Given this list of marker genes MKNK2, SP100, CIB1, BAG3, BMP4, BCL2L2 (NCBI Gene Id 599), GPER1, TERT, WWOX, FAIM, TLR6, IL1B, TNFRSF10C, KRT18, NRG1, MAPK7, GATA1, RAF1, ITGAV, SNAI2 (NCBI Gene Id 6591), G0S2 (G0/G1 switch 2), PDIA3, ACSL5, TNFSF15, PPP2R1B, IL19, SCRT2, AKT1, ZSWIM2, CD40LG, ZMYND11, NOS3, SGPP1, PTPRC, TLR3, HTT, SERPINE1, TNFRSF10B, SPI1, BEX3, SORT1, STK3 (serine/threonine kinase 3), LMNA, FAIM2, STX4, LGALS3, TNFSF11, IFI27, GPX1, TRAF2, RBCK1, DAXX, SIAH2, UNC5B, MCL1, LCN2, TNFRSF1A, IL2, IL1A, DBH, HGF, CD70, IL7, BOK, JAK2, GABARAP, PAK2, CASP8AP2, BAX, TGFB2, APP, FASLG, ZDHHC3, STK4, HSPA1B, NDUFA13, FADD, SMAD4, IFI6 (NCBI Gene Id 2537), TNFRSF1B, PHIP, FEM1B, GSK3B, AGTR2, SFRP2, HTRA2, FAF1, GCLM, RELA, PARP2, PPP2R1A, CX3CL1, PSME3, DDX3X, MIR221, TNFSF12, NGF, RNF34 (ring finger protein 34), LTA, ARHGEF2, BCL2L14 (BCL2 like 14), RB1CC1, PRDX2, TNFAIP3, NRP1, BCL2A1, SIVA1, BMPR1B, BCL10, SMAD3, MIR142, CFLAR, PMAIP1, GFRAL, HIPK1, MIR199A1, DEDD, SH3RF1, SGK3, GDNF, EYA1, SRPX, NF1 (NCBI Gene Id 646021), TNFRSF12A, TCF7L2, FGFR1, CAV1, KLF4, EYA4, BLOC1S2, LTBR, TRADD, RPS6KB1, DAB2IP, PAK5, FYN, RNF41, BCL2L11, MIR222, SFRP1, BAK1, DIABLO, FAS, TLR4 (toll like receptor 4), NGFR, TNF, CTNNA1, ITM2C, MAP2K5, TMBIM1, GRINA, P2RX7, ITGA6, COL2A1, BAD, EYA2, PF4, INHBA, SKIL, PELI3, BCL2L1, CD27, IFNG, RET, DEPTOR, TRAF1, PDPK1, BRCA1, MADD, CASP8, PEA15, ERBB3, DDX47, STRADB, ACVR1, BID, LTB, DELE1, KRT8, CYLD, TMC8, FGB, IGF1, FGFR3, BCL2, MOAP1, C8orf44-SGK3, RIPK1, MLLT11, TNFSF10, GCLC (NCBI Gene Id 2729), FGA, BMP5, KITLG, NFKBIZ, FOXO3, PIK3R1, AR, CASP2, IL33, IL6R, HMGB2, TGFB1, MAL, HSPA1A, BCL2L10, NOL3, DAPK1, ATF3, HMOX1, PPP1CA, PML, ICAM1, DEDD2, CSF2, PIDD1, GSTP1, THBS1, SCG2, ITPRIP, ACVR1B (activin A receptor type 1B), GSK3A, AGT, PARK7, TNFRSF10A, PYCARD, TGFBR1, IL12A, BIRC6, FGF10, TNFSF14, CRADD, YAP1, RFFL, EYA3, HYAL2, CTTN, FGG, SRC (NCBI Gene Id 6714), here is a description of the gene set: Human Gene Set: GOBP_EXTRINSIC_APOPTOTIC_SIGNALING_PATHWAY studied in species Homo sapiens The series of molecular signals in which a signal is conveyed from the cell surface to trigger the apoptotic death of a cell. The pathway starts with either a ligand binding to a cell surface receptor, or a ligand being withdrawn from a cell surface receptor (e.g. in the case of signaling by dependence receptors), and ends when the execution phase of apoptosis is triggered.